The following is a description of a gene set: Mouse Gene Set: GOMF_MICROTUBULE_MOTOR_ACTIVITY studied in species Mus musculus A motor activity that generates movement along a microtubule, driven by ATP hydrolysis., and this is the list of marker genes: Kif2c, Dnah17, Kif20a, Dnah10, Kif16b, Kif6, Dnhd1, Kifc3, Kif26a, Dync1i1, Kif15, Kif19a, Kifc1, Kif3b, Kif2b, Dnai2, Kif5a, Kif3c, Kifc5b, Kif5b, Kif18a, Kif20b, Dnah7c, Dnah12, Cenpe, Kif3a, Kif2a, Dnah1, Kifc2, Dnah5, Kif18b, Dnah14, Dync1li1 (dynein cytoplasmic 1 light intermediate chain 1), Kif23, Kif1b, Kif27, Dync2h1, Kif21b, Dnah7b, Stard9, Kif1a, Kif21a, Dnah3, Dnah2, Kif26b, Kif13a, Kif28, Kif9, Dnah7a, Kif4, Kif14, Kif17, Kif24, Kif1c, Kif19b, Kif13b, Dnah8, Kif22, Kif11, Kif12, Dnah6, Dnah11, Kif5c, Kif7, Dync1h1, Dnah9